The following is a description of a gene set: Hypoxia-dependent proliferation of myoblasts studied in species Mus musculus Mouse Gene Set: WP_HYPOXIADEPENDENT_PROLIFERATION_OF_MYOBLASTS, and this is the list of marker genes: Smad3, Smad2, Ddit4, Igf1, Vegfa, Hgf, Rheb, Mtor (mechanistic target of rapamycin kinase), Tsc2, Akt1, Trim63, Tsc1, Fgf1, Mstn, Myog, Myod1, Fbxo32, Myf5, Calca